Given this list of marker genes Dpyd, Dpys, Nt5c3, Nt5c, Upp1, Nt5m, Upb1, here is a description of the gene set: The chemical reactions and pathways resulting in the breakdown of dUMP, deoxyuridine (5'-)monophosphate. Mouse Gene Set: GOBP_DUMP_CATABOLIC_PROCESS species: Mus musculus